Given this list of marker genes NUP62, DGKD, SNX6, SH3TC2, MIR21, ADRA2A, ACP4, WDR54, CCDC88A, GPRC5A, RALA, PTPN18, MIR29A, CNOT9, AQP5-AS1, AGR2, VPS25, SNX5, HIP1, CBLC, ERRFI1, EGFR, RTN4, TGFB1, PTPRJ, NPPA, HAP1, ITGA1, AGT, SOS1, PTPN3, DUSP3, ZFYVE28, PTK6, SH3GL2, NEU3, RBPJ, FASLG, ZGPAT, MIR133A1, FAM83B, PTPN2 (NCBI Gene Id 5771), MVP, PLAUR, TSG101, CBL, SPRY2, GPER1, SOCS4, CHMP6, RALB, CDH13 (cadherin 13), CEACAM1, FER, RNF115, MVB12A, MMP9, IFI6, MVB12B, RNF126, AFAP1L2, SOCS5, ADAM17 (NCBI Gene Id 6868), CBLB, SHKBP1, RHBDF2, RAB7A, PDE6G, FBXW7, DAB2IP, RHBDF1, LGMN, PDE6H, PTPN12, HIP1R, here is a description of the gene set: Any process that modulates the frequency, rate or extent of ERBB signaling pathway. Human Gene Set: GOBP_REGULATION_OF_ERBB_SIGNALING_PATHWAY studied in species Homo sapiens